Given this list of marker genes NUP188, SIAH1, KAT6A (lysine acetyltransferase 6A), SMARCA2 (NCBI Gene Id 95083), TCF4, here is a description of the gene set: Sparse medial eyebrow species: Homo sapiens Human Gene Set: HP_SPARSE_MEDIAL_EYEBROW Decreased density/number and/or decreased diameter of medial eyebrow hairs.